The following is a description of a gene set: Reactome Pathway: Defective ABCA3 causes SMDP3_5683678 part of: ABC transporter disorders studied in species Homo sapiens ATP-binding cassette sub-family A member 3 (ABCA3) is thought to play a role in the formation of pulmonary surfactant by transporting lipids such as cholesterol into lamellar bodies (LBs) in alveolar type II cells. In LBs, surfactant proteins and lipids are assembled into bilayer membranes that are secreted into the alveolar airspace, where they form a surface film at the air–liquid interface. Defects in ABCA3 can cause pulmonary surfactant metabolism dysfunction 3 (SMDP3), a usually fatal pulmonary disease in newborns, characterised by the absence of normal LBs and the presence of electron-dense inclusions within small vesicular structures. Loss of secretion of lipid pulmonary surfactants causes excessive lipoprotein accumulation in the alveoli resulting in severe respiratory distress., and this is the list of marker genes: ABCA3